Given this list of marker genes FDX2, PTGIS, POR, FDXR, NR1H4, CYP8B1, CYP4F2, CYP1A2, CYP27B1, CYP51A1, CYP26B1, CYP2C9, CYP2S1, CYP3A4, CYP2R1, CYP4V2, CYP4A22, CYP2A6, CYP7B1, CYP2A13, CYP2B6 (NCBI Gene Id 82059), CYP11B2, CYP2C18, CYP4F3, CYP2C19, CYP39A1, RXRA, CYP1A1, CYP3A43, CYP4F11, CYP26A1, NCOA1, CYP11B1, NCOA2, CYP46A1, CYP4F22, TBXAS1, CYP2E1, FDX1, CYP2U1, CYP2W1, CYP4A11, CYP4F12, CYP3A5, POMC, CYP27A1, CYP2D6, CYP7A1, CYP11A1, CYP1B1, CYP3A7, CYP2C8, CYP26C1, CYP2J2, AHR, CYP4F8, CYP21A2, CYP24A1, CYP19A1, CYP2F1, CYP4B1, ARNT, CYP2A7, ARNT2, here is a description of the gene set: studied in species Homo sapiens Cytochrome P450 - arranged by substrate type Human Gene Set: REACTOME_CYTOCHROME_P450_ARRANGED_BY_SUBSTRATE_TYPE